The following is a description of a gene set: studied in species Mus musculus Mouse Gene Set: GOBP_POSITIVE_REGULATION_OF_ERBB_SIGNALING_PATHWAY Any process that activates or increases the frequency, rate or extent of ERBB signaling pathway., and this is the list of marker genes: Cnot9, Rala, Ralb, Sos1, Agt, Ccdc88a, Hip1r, Adam17, Tgfb1, Hap1, Gper1, Hip1, Esr2, Plaur, Esr1, Shkbp1, Spry2, Agr2, Neu3, Egfr, Afap1l2, Adra2a, Fasl, Fam83b, Dgkd, Rtn4, Pde6g, Rbpj, Pde6h, Mmp9